Given this list of marker genes CYBA, NCF4, IGKC, NCF2, CTSC, PKHD1, IRAK4, NCF1, CYBC1, CYBB, IGHG2, ABCB4 (ATP binding cassette subfamily B member 4), here is a description of the gene set: Liver abscess Human Gene Set: HP_LIVER_ABSCESS A circumscribed area of pus or necrotic debris in the liver. species: Homo sapiens